Given this list of marker genes TRIL (NCBI Gene Id 9865), G6PC3, SMAD9, SCAF11, GRIN2D, CTDSP2, HMBOX1, MDN1, DNAAF9, TUB, TRPV3, CLPP, RAB11FIP1, PHB1, COL27A1, SAMD9L, GRIA3, PAIP2, OTULIN, XPR1, MEGF11, VPS4B (vacuolar protein sorting 4 homolog B), PLK2, RHOT2, RARA, EML1, ZNF652, KAT7, GATA6, ZFP82, SSH1, CRKL, HAPLN1, PLCL2, FBXO30, NEMP2, GRM5, SRGAP2, MCF2L, B3GNT7, RELN, PGAP1, UBE2W, WEE1, TXNIP, IL13RA1, ING5, SNX12, PPP4C, ATXN10, SASH1, CACNG2, TET1, SLIT2, DCC (DCC netrin 1 receptor), ARID1B, CACNA2D3, STK32A, STRN4, SAMD12, AFF3, SNX18, GPD2, GRIA4, MIPOL1 (NCBI Gene Id 8107), FEM1B, BCORL1, RAB20, GEM, GABBR2, ERC2, EPB41L4A, GIGYF2, CBLB, C1orf21, CSRP2, MAPKAPK3 (MAPK activated protein kinase 3), PTPRQ, PCNX1, NXT2, DPP10, RETREG3, PTPRT, SOCS6, UBE2V1, ARHGAP12, NRP2, EPB41L1 (erythrocyte membrane protein band 4.1 like 1), SLC39A7, SLC5A3, COL5A1, NUS1, BLTP1, CA10, YWHAB, SS18, CDCP1, GALNT3, EEIG1, TNFRSF10D, CXADR, GPAM, SETD7, WNK1 (WNK lysine deficient protein kinase 1), EIF2S2, ONECUT2, MBTD1, NRXN1, STIM2, SOCS5 (suppressor of cytokine signaling 5), MME (NCBI Gene Id 4311), INO80D, ARHGAP32, IFFO2, SZRD1, MNT, ZNF800, SPTY2D1, EYA4, SOS1, EFR3A, FAM177A1, TCEA1, HIP1, SNAP25, ECE1, SLC6A1, LBH, RND3, CHTF8, GRIK3, CDH24, ARHGEF38, BEND4, NF1, CCNT2, COL21A1, FBXW7, CA7, MAPK14, PDPK1, ITCH, GXYLT1, SP2, GREM1, ENAH, UBR1, AMER2, MIER2, PLPPR1, ANKRD40, ITPKC, OSBPL10, ZFP36L1, MTA3 (metastasis associated 1 family member 3), SLC22A23, SMAD2, TTC9, FSD2, F3, CCDC92, TTC39B, CDIP1, GCNT2, FRMPD3, EPHB2, MBOAT2, MINPP1, NALF1, ASPH, WNT3A, PDE10A, SLC35F1, ABCA12, LTBP1, CYP39A1, RO60, VANGL1 (NCBI Gene Id 81839), IFITM10, FOXA3, RPS6KA5 (ribosomal protein S6 kinase A5), FRYL, PPM1E, VANGL2, UNC13C, FAM78A, CNOT6 (CCR4-NOT transcription complex subunit 6), ZNF618, NPTXR, CEP76, PLAGL2, ATP8A1, STOX2, RAP1B, SPG21, RECK, NALF2 (NCBI Gene Id 27112), GTF2A2, PPME1, ZNF84, MYT1, TMEM64, ELMO1, RSBN1L, RNF38, BMI1, COMMD3-BMI1, PHF6, NRK, SH3RF1, KCNK2, SLC7A11, MOSPD3, SMARCA2, TMEM87A, SKA3, TGFBR1, SLC35F3, PROSER2, SEC24A, ZDHHC17, PPP1CC (NCBI Gene Id 5501), LHFPL3, ISL1, RNF144A, N4BP1, PDS5B, HYCC2, HIC1, ZNF704, REPS1, DCP1A, FNDC4, NAV2 (NCBI Gene Id 89797), UTP15, VEGFC, NRBF2, SCAI, PDHX, SH2D3C, COLGALT2, SEC22A, KDM7A, STK35, IRS1, DPY19L4, RGL2, DNAAF6, PDE7B, USP49 (ubiquitin specific peptidase 49), NAA50, DHTKD1, UBE2N, NGFR, ADCY2, TEAD1, AKR7A2, UBN2, MET (MET proto-oncogene, receptor tyrosine kinase, NCBI Gene Id 4233), RNGTT, NKX3-1, NEO1 (neogenin 1), CCDC88A, MDH1B, WDR7, CDS1, GCC1, USH2A, ZC3H12D, NEURL4, SMAP1, CLDN18, DBF4B, SP1, DOT1L (DOT1 like histone lysine methyltransferase), NFIL3, DCUN1D4, ADAMTS5, OPHN1, RNF182, TPPP, STK24, KIRREL1, ABCB9, RPS6KB1, TNPO1, PTPRB, MATN3, IRF4, MOSMO, PLCH1, SAMD10, AK2, DISC1, SHTN1, AMD1, RCAN2, KCNK10, RCOR3, KDM3A, MTMR4, JAG1, MLLT10, CA12, RETREG1, TMC7, TMEM167A, CASC3, ROR1, RASGEF1B, STX7 (syntaxin 7), SYT1, TMEM25 (transmembrane protein 25), STAG1, ZFHX3, PNKD, ST14, ECE2, GPATCH2L (G-patch domain containing 2 like), SIRT1, AFF4, LITAF, PRKX, ALDH4A1, FBLN5, BAZ2B, AKIRIN1, MTCL2, DENND1B, FAM184A, TTC39A, DCX, SLC26A11, MED14, NFX1, IGSF3, PITPNM2, DPY19L3, SFXN2, PALS2, HCN4, ARRDC4, GAPT, ARF3, NABP1, ABL2, ERLEC1 (endoplasmic reticulum lectin 1), CKAP4, FXR2, HYCC1, CABLES2, ZBTB20, MIEF1, CCNC, LIMK1, GSK3B, CREB1, PTAR1, RAB39B, MSL1, HECTD1, GLTP, IGLON5, UGCG, KLHDC8A, DIRAS1, PTPN9, LYPD3 (LY6/PLAUR domain containing 3), MAP2K7, NSD1, MED13L, MSI2, TMEM30A, HOXA5, KBTBD11, MAPK8IP3, INSR, USP42, FBLN2, COPB2, NEK2, SH3BGRL2, APBA2 (NCBI Gene Id 9029), ARHGAP21, SOX7, MARK4, UNC80, KCNN3, UBE2E2, CNTLN, KMT2A, CSF1, NEUROD6, SEC61A1, TRIM23, OPA1, ST6GALNAC3, C1QTNF7, CEMIP, POGZ, CCN4, RET, ZKSCAN2, SPATA17, GLRA2, AK4, SLC24A4, GCC2, PPFIA2, MMD, TMTC2, UBR5, CCNK, H3-5, WBP1L, MED12L, PDE3A, UBA6, EEF1AKMT4-ECE2, BICC1, PDIA5, SREK1, CECR2, USP46, GNS, POGLUT1, RYBP, DTX4, SGMS1, UGT8, YAF2, GSPT1, SORL1, MTSS2, H3-3B, PHF24, PAX9, BAG2, ITGA5, ARMC8, RERE, LPAR6, MTDH, MSTO1, GAB1, GALNT7, SERTAD2, NDST1, NREP, APOLD1, ABHD17C, here is a description of the gene set: studied in species Homo sapiens Genes predicted to be targets of miRBase v22 microRNA hsa-miR-216a-3p in miRDB v6.0 with MirTarget v4 prediction scores > 80 (high confidence targets). from publication Chen Y, Wang X (PMID 31504780) Human Gene Set: MIR216A_3P